Given this list of marker genes Yap1, Esr1, Stat5a, Aph1a (aph1 homolog A, gamma secretase subunit), Psen1, Ncstn, Src, Erbb4, Wwox, Psenen, Aph1b, here is a description of the gene set: Nuclear signaling by ERBB4 Mouse Gene Set: REACTOME_NUCLEAR_SIGNALING_BY_ERBB4 species: Mus musculus